The following is a description of a gene set: Mouse Gene Set: CUI_T_CELL_GD_IL19_RESPONSE_DN Genes negatively differentially expressed in cell type: γδ T cell upon treatment with cytokine: IL-19 in mouse lymph nodes in vivo. Cytokines mediate cell-cell communication in the immune system and represent important therapeutic targets. A myriad of studies have highlighted their central role in immune function, yet we lack a global view of the cellular responses of each immune cell type to each cytokine. To address this gap, the authors created the Immune Dictionary, a compendium of single-cell transcriptomic profiles of more than 17 immune cell types in response to each of 86 cytokines (>1,400 cytokine-cell type combinations) in mouse lymph nodes in vivo. A cytokine-centric view of the dictionary revealed that most cytokines induce highly cell-type-specific responses. For example, the inflammatory cytokine interleukin-1β induces distinct gene programmes in almost every cell type. A cell-type-centric view of the dictionary identified more than 66 cytokine-driven cellular polarization states across immune cell types, including previously uncharacterized states such as an interleukin-18-induced polyfunctional natural killer cell state. species: Mus musculus from publication Cui A, Huang T, Li S, Ma A, Pérez JL, Sander C, Keskin DB, Wu CJ, Fraenkel E, Hacohen N (PMID 38057668), and this is the list of marker genes: Fos, Hspa8, Emb, Ubc, Junb, Fosb